Given this list of marker genes Akr1c18, Dolk, Dpm2, Dpm3, ENSMUSG00000144291, Srd5a3, Dpagt1, Dhdds, Nus1, Dpm1, here is a description of the gene set: studied in species Mus musculus The chemical reactions and pathways involving polyprenols, prenols with more than 4 isoprenoid residues, which may be all-trans, or a mixture of cis and trans. Mouse Gene Set: GOBP_POLYPRENOL_METABOLIC_PROCESS